The following is a description of a gene set: studied in species Homo sapiens Human Gene Set: HP_LISSENCEPHALY A spectrum of malformations of cortical development caused by insufficient neuronal migration that subsumes the terms agyria, pachygyria and subcortical band heterotopia. See also neuropathological definitions for 2-, 3-, and 4-layered lissencephaly. Lissencephaly, and this is the list of marker genes: RNU4-2, MCM7, MCPH1, TUBA1A, TP73, FTO, DAG1, SRPX2, RAB3GAP2, CDKL5, VLDLR, AXIN1, OCLN, RTL1, GRM7, TBC1D20, HIC1, GFM2, LAMB1, GRIN1, CRPPA, TPRKB, KCNA1 (NCBI Gene Id 729214), CEP152, PEX2 (peroxisomal biogenesis factor 2), ATP6V1E1, ATP6V1A, PPFIBP1, PIK3R2, GPX4, ATR (ATR serine/threonine kinase), MLYCD, FOXG1, TUBG1, NFIX, KIFBP, FKRP, KIF14, TP53RK, WDR26, NUP107, VPS33B, SLC30A9, DMXL2, DHCR24, EXOSC5, FKTN, SASS6, ALG12, CEP85L, ATP6V0A2, CASK, PI4KA, PEX10, WDR62, NEUROD2, ISCA1, DLK1, RTTN, POMK, TRAPPC14, NUP133, NDE1, WARS1, PNKP, SNF8, PHC1, SNAP29, ARX, RAB3GAP1, YWHAE, GNAO1, POMT1, NARS1, CTNNA2, NEK1, LMNB1, FBXO28, DYNC1H1, STIL, PIGP, RXYLT1, DCX, PHGDH, CAMSAP1, PEX13, PAFAH1B1, LAMC3, CEP135, FAT4, TUBGCP6, ETFA, FRMD5, B4GAT1, PLP1, PIDD1, MTOR, SLC25A22, BLTP1, SIK1, KAT6B (NCBI Gene Id 23522), POMGNT2, CRADD, CIT, SCN2A, PDHB, GMPPB, MACF1, MPDZ, AKT3, ZNHIT3, METTL5, CPT2, CASP2, POMGNT1, COPB2, ANKLE2, ACTB, KATNB1, ETFDH, CEP63, TMTC3, APC2, TUBB3, NCAPD3 (non-SMC condensin II complex subunit D3), CDK5, SARS1, LARGE1, TCTN2, EML1, RRAGC, POMT2, MEG3, VAC14, PSAT1, FIG4, ADGRG1, CEP295, SLC32A1, SCN1B, TUBB, OSGEP, CTU2, STS, VIPAS39, CDK5RAP2, NUP37, PRKDC, FH, FLI1, ETFB, WDR73, TUBB2B, CSNK2A1 (NCBI Gene Id 1457), TUBGCP2, COL4A1, PIK3CA, MFSD2A, WDR4, RMND1 (NCBI Gene Id 55005), NSDHL, GON7, RAB18, TCTN1, DCHS1, KNL1, LAMA2, TRIM8, KIF2A, CENPE, CCBE1 (collagen and calcium binding EGF domains 1), YRDC, B3GALNT2, SLC25A19, TMX2, CDK6 (cyclin dependent kinase 6), TRAPPC10, PYCR2, ASPM, TAF13, PIGQ, ADAMTS3, ACTG1, CCDC88A, RELN, TBR1 (T-box brain transcription factor 1), ARHGAP31, LAGE3 (NCBI Gene Id 8270), RNU4ATAC